The following is a description of a gene set: species: Homo sapiens Evagination of a membrane to form a synaptic vesicle. Human Gene Set: GOBP_SYNAPTIC_VESICLE_BUDDING, and this is the list of marker genes: AP3S2, DNM1, MX1, BTBD8, DNM2 (dynamin 2), SLC2A4, MX2, AP3S1, AP3B2, AP3M2, AP3D1, AP1G1 (adaptor related protein complex 1 subunit gamma 1), DNM3